Given this list of marker genes ADCY7, ADCY9, FCGR3A, IGHV1-46, PRKACG, IGKV1-39, IGHG2, IGKV1-16, IGKV1-12, IGHV3-33, IGKV3-20, IGLC3, IGHV1-69, ADCY8, IGLV2-8, IGLV1-51, PRKAR2A, IGLV6-57, IGHV1-2, IGKV2D-28, IGKV1D-33, IGKV1D-39, FGR, IGKV1D-12, ITPR2, IGHV2-70, IGKV2-30, CD3G, IGLV2-14, ADCY2, ITPR1, PRKAR1B, PRKAR2B (NCBI Gene Id 5577), IGKV4-1, IGKV3-15, YES1, IGLV2-11, IGLV3-19, IGHV4-59, IGHV3-30, FCGR1A, IGLV7-43, PRKX, HCK, IGKV3-11, CREB1, PLCG2, AHCYL1, IGLC2, IGKV2D-40, IGHV3-7, IGKV5-2 (NCBI Gene Id 28907), IGLV3-21, CD247, IGLV3-27, ADCY6, IGKV2-28, PLCG1, IGLV2-23, SYK, ADCY1, PRKAR1A, IGHV4-34, IGKV1-5, PRKACA (NCBI Gene Id 5566), IGHG1, IGLV1-47, IGLV1-44, IGHV3-53, IGLV1-40, FYN, IGHV3-13, CALM1, IGKV3D-20, IGKV1-33, IGHV3-11, ADCY3, IGHV2-5 (NCBI Gene Id 28457), IGLV3-1, LYN, PRKACB, IGHV3-23, IGHV4-39, IGHV3-48, IGLV3-25, ADCY5, ADCY4, IGKV2D-30, IGKV1D-16, SRC, IL10, IGHG4, FCGR2A, ITPR3, IGKV1-17, here is a description of the gene set: studied in species Homo sapiens Human Gene Set: REACTOME_FCGR3A_MEDIATED_IL10_SYNTHESIS FCGR3A-mediated IL10 synthesis